Given this list of marker genes Ly6a, Stat1, Pnp, Samhd1, Slc8b1, Mndal (NCBI Gene Id 192690), Phf11d, Ccdc86, Ppa1, Trim30a, Isg15, Lgals9, Mvp, Otulinl, Cpne2, Ifitm3 (NCBI Gene Id 66141), Ifi205, Ifi204, Grn, Ly6e, Ly6c2, Sdc3, Lgals3bp, Id2, Ptms, S100a6, Selenow, Psma4, Ifi211, Ifi44, Cxcl9, Acadl, Pttg1, Isg20, Ifi35, Plaa (phospholipase A2, activating protein), Ogfr, Bst2, Chmp4b, Tspo, Irf7, Anxa1, Xaf1, B2m, Svbp, Rnf213, Hspa8, Sp110, Zbp1, Phf11b, Sct, H2-T23, Phf11a, Oas3, Trim30d, Ube2l6, Dhx58, Plekho1, Txn1, Aimp2, Akr1a1, Sp100, here is a description of the gene set: species: Mus musculus Mouse Gene Set: CUI_CDC1_IFNE_RESPONSE_UP Cytokines mediate cell-cell communication in the immune system and represent important therapeutic targets. A myriad of studies have highlighted their central role in immune function, yet we lack a global view of the cellular responses of each immune cell type to each cytokine. To address this gap, the authors created the Immune Dictionary, a compendium of single-cell transcriptomic profiles of more than 17 immune cell types in response to each of 86 cytokines (>1,400 cytokine-cell type combinations) in mouse lymph nodes in vivo. A cytokine-centric view of the dictionary revealed that most cytokines induce highly cell-type-specific responses. For example, the inflammatory cytokine interleukin-1β induces distinct gene programmes in almost every cell type. A cell-type-centric view of the dictionary identified more than 66 cytokine-driven cellular polarization states across immune cell types, including previously uncharacterized states such as an interleukin-18-induced polyfunctional natural killer cell state. Genes positively differentially expressed in cell type: cDC1 (conventional dendritic cell type 1) upon treatment with cytokine: IFN-ε in mouse lymph nodes in vivo. from publication Cui A, Huang T, Li S, Ma A, Pérez JL, Sander C, Keskin DB, Wu CJ, Fraenkel E, Hacohen N (PMID 38057668)